Given this list of marker genes Sdc3, Ndst2, Ext1, Slc35d2, Gpc2, Hs6st1, Hs3st4, Hs3st2, Hs6st3, Ndst3, Gpc3, Hs3st3b1, Hs6st2, Sdc1, here is a description of the gene set: This event has been computationally inferred from an event that has been demonstrated in another species.<p>The inference is based on the homology mapping from PANTHER. Briefly, reactions for which all involved PhysicalEntities (in input, output and catalyst) have a mapped orthologue/paralogue (for complexes at least 75% of components must have a mapping) are inferred to the other species. Reactome Pathway: HS-GAG biosynthesis part of: Heparan sulfate/heparin (HS-GAG) metabolism species: Mus musculus electronically inferred by orthology from the curated human pathway